Given this list of marker genes MAP2K2, ARRB2, SRC, IL17RD, CNKSR2 (NCBI Gene Id 22866), VCL, ITGA2B, ARRB1, HRAS, MAP2K1, RAF1, KRAS, ITGB3 (integrin subunit beta 3), NRAS, TLN1, VWF, ACTG1, LAMTOR3, KSR2, CNKSR1, LAMTOR2, FGG, FGA, RAP1A, IQGAP1, YWHAB, BRAF, APBB1IP, FN1, WDR83, ACTB, MARK3, CSK, ARAF, FGB, MAPK1, KSR1, RAP1B, MAPK3, PEBP1, here is a description of the gene set: Reactome Pathway: MAP2K and MAPK activation Activated RAF proteins are restricted substrate kinases whose primary downstream targets are the two MAP2K proteins, MAPK2K1 and MAP2K2 (also known as MEK1 and MEK2). Phosphorylation of the MAPK2K activation loop primes them to phosphorylate the primary effector of the activated MAPK pathway, the two MAPK proteins MAPK3 and MAPK1 (also known as ERK1 and 2). Unlike their upstream counterparts, MAPK3 and MAPK1 catalyze the phosphorylation of hundreds of cytoplasmic and nuclear targets including transcription factors and regulatory molecules. Activation of MAP2K and MAPK proteins downstream of activated RAF generally occurs in the context of a higher order scaffolding complex that regulates the specificity and localization of the pathway. part of: RAF/MAP kinase cascade studied in species Homo sapiens